The following is a description of a gene set: studied in species Homo sapiens Atopic dermatitis mechanism and therapies Human Gene Set: WP_ATOPIC_DERMATITIS_MECHANISM_AND_THERAPIES, and this is the list of marker genes: MS4A2, FCER1A, OSMR, IL2RG (NCBI Gene Id 3561), IL31RA, IL25, JAK3, IL4R, IL1RL1 (NCBI Gene Id 9173), TYK2, STAT3, TSLP, STAT6, FCER1G, DEFB103A, IL4, IL5, IL13, DEFB103B, IL13RA1, IL33